Given this list of marker genes HSD17B10, SRD5A2, AKR1B15, DHRS9, AKR1C3, HSD17B1, AKR1C4, HSD17B6, HSD17B2, DHRS1, AKR1C1, HSD17B8, HSD17B3, here is a description of the gene set: species: Homo sapiens Human Gene Set: GOMF_TESTOSTERONE_DEHYDROGENASE_NAD_P_PLUS_ACTIVITY Catalysis of the reaction: testosterone + NAD(P)+ = androst-4-ene-3,17-dione + NAD(P)H + H+.